The following is a description of a gene set: studied in species Mus musculus The biological process whose specific outcome is the progression of the lung epithelium from an initial condition to its mature state. This process begins with the formation of lung epithelium and ends with the mature structure. The lung epithelium is the specialized epithelium that lines the inside of the lung. Mouse Gene Set: GOBP_LUNG_EPITHELIUM_DEVELOPMENT, and this is the list of marker genes: Yap1, Dhcr7, Adamtsl2, Foxa2, Map2k2, Pkd1, Hmga2, Rbpj, Rcn3, Shh, Wnt2, Cdc42 (cell division cycle 42), Foxp4, Foxp1, Stra6, Fosl2 (fos-like antigen 2), Hoxa5, Agr2, Fgfr4, Foxa1, Ascl1, Gata6, Ctnnb1, Rbbp9, Klf2, Errfi1, Fgf10, Foxp2, Tmem38b, Col6a1, Bmp4, Spdef, Fgfr3, Thra, Kras, Thrb, Trp73, Fndc3b, Grhl2, Creb1 (cAMP responsive element binding protein 1), Pthlh, Fgfr2, Wnt7b, Sav1, Ncor2, Sox9, Ppp3r1, Nkx2-1, Aimp2, Foxj1, Srsf6, Nfib, Fgf7, Map2k1, Igf1, Lta4h